The following is a description of a gene set: Neighborhood of MATK Human Gene Set: GNF2_MATK species: Homo sapiens Neighborhood of MATK megakaryocyte-associated tyrosine kinase in the GNF2 expression compendium, and this is the list of marker genes: S1PR5, GZMM (NCBI Gene Id 3004), GZMH, ARL4C, CTSW, NKG7, PTGDR, CD247 (CD247 molecule), ZAP70, IL2RB, ARHGEF3, PTPN4, MATK, KLRD1, RASSF1, SUN2, ABHD17A, GZMA, PRKCH, IL18RAP, KLRK1, KLRB1, PRF1, BTN3A3